The following is a description of a gene set: Genes containing one or more binding sites for (ZNF165) in their promoter regions (TSS -1000,+100 bp) as identified by GTRD version 20.06 ChIP-seq harmonization. from publication Yevshin I, Sharipov R, Kolmykov S, Kondrakhin Y, Kolpakov F (PMID 30445619) studied in species Homo sapiens Human Gene Set: ZNF165_TARGET_GENES, and this is the list of marker genes: CDKN1B, MIDN, MFSD12, MIR137HG, GPR39, YARS1, CYP2R1, RASSF1-AS1, BTG1, ZMPSTE24-DT (NCBI Gene Id 120017338), MIRLET7IHG, ST3GAL6, RICTOR, PISD, OPLAH, PTEN, STRIP1, ANKRD33BP1 (NCBI Gene Id 100419920), CMTR1, IQCN, LRRC71, ECI1, SNORD12C, SPAG1, PTPN1, ITGB2, SLC22A5, ABCC4, RAB10, MOB3A (NCBI Gene Id 126308), CDC123, RFC2, MTCL2, ZNF503-AS2, UBQLN1-AS1, NMRK1, SAC3D1, BTG1-DT, ESYT2, ERI1, ABCB6, TBC1D4, RPS14, ATL2, GARNL3, SPSB2, UBQLN1, TCEANC2, ZMPSTE24, EML6, FGF9, ZNFX1, CST3, PTPRG, TMEM179B, CDKN1C, RIN3, TMTC4, PRSS12, SPPL2A, ITM2C (NCBI Gene Id 9523), SEPHS1, STK10, NPEPL1, LINC03052, BMPR1A, LINC01843, SEC24D, RCAN1, FANCC, MYLK, UQCC1, LINC01730, ADPGK, ATF6-DT, SLC17A5, FBF1, ATF6, CYP1B1, FUT11, IZUMO4, ZNF7, NUDT5, ZFAS1, ST3GAL6-AS1, PPP1R12C